Given this list of marker genes Tns3, Bnip2, Gpr55, Plxnb1, Sos1, Pdgfrb, Apoa1, Akap13, Reln, Lpar1, Mcf2l, Abra, Nrg1, Cdon, Pik3cg, Adgrg1, Dynlt1a, Auts2, Epo, Notch2, Rasgrp1, Agrn, Itpkb, Synpo2l, Ntrk1, Musk (muscle, skeletal, receptor tyrosine kinase), Shoc2, Ngf, Arhgef3, Rasgrf1, Pik3cb, Crkl, Lpar2, Dock2, Erbb2, Adcyap1r1, Col3a1 (NCBI Gene Id 98713), Ngfr, Arrb1, Rtn4r, Csf1, Hras, Camk2d, Igf1, Rasgef1a, Frmd7, Rtn4 (reticulon 4), Map2k1, Crk, F2rl1 (NCBI Gene Id 14063), Sos2, Fxr1, Kras, Picalm, Dynlt1b, Mmd2, Notch1, Tgm2, F11r, Src (NCBI Gene Id 99351), Robo1, Dgki, Mapre2, F2r, Fgf10, Dok7, Net1, Kitl, Itgav, Gpr4, Prag1, Dynlt1f (NCBI Gene Id 100040631), Map4k4, Sema4d, Csnk1a1, Fermt2, Stk19, Fnta, Lrp4, Dynlt1c, here is a description of the gene set: Mouse Gene Set: GOBP_POSITIVE_REGULATION_OF_SMALL_GTPASE_MEDIATED_SIGNAL_TRANSDUCTION Any process that activates or increases the frequency, rate or extent of small GTPase mediated signal transduction. species: Mus musculus